The following is a description of a gene set: Genes down-regulated in T cell acute lymphocytic leukemia (T-ALL) patients refractory to chemotherapy treatment. Human Gene Set: CHIARETTI_T_ALL_REFRACTORY_TO_THERAPY Gene expression profiles were examined in 33 adult patients with T-cell acute lymphocytic leukemia (T-ALL). Nonspecific filtering criteria identified genes differentially expressed in the leukemic cells. Hierarchical clustering of samples identified 2 groups that reflected the degree of T-cell differentiation but was not associated with clinical outcome. Comparison between refractory patients and those who responded to induction chemotherapy identified a single gene, interleukin 8 (IL-8), that was highly expressed in refractory T-ALL cells and a set of genes that was highly expressed in leukemic cells from patients who achieved complete remission. We next identified genes that were differentially expressed in T-ALL cells from patients who either had a relapse or remained in continuous complete remission. A model based on the expression of 3 of these genes was predictive of duration of remission. The 3-gene model was validated on a further set of T-ALL samples from 18 additional patients treated on the same clinical protocol. This study demonstrates that gene expression profiling can identify a limited number of genes that are predictive of response to induction therapy and remission duration in adult patients with T-ALL. studied in species Homo sapiens from publication Chiaretti S, Li X, Gentleman R, Vitale A, Vignetti M, Mandelli F, Ritz J, Foa R (PMID 14684422), and this is the list of marker genes: MME, CXCL8, LINC03124, NID2, EPHB6, H2AC6, DHCR24, HOXA9, TCF7, NOTCH3, TFDP2, ARL4C, PSPHP1, PSPH, DNTT, MXI1, CR2, ADA, GFI1, PRDX2, FGFR1, FHL1, TMPO, SELL, PCDH9, ICOS, FYB1 (FYN binding protein 1), MX1, BCL6, H1-0